Given this list of marker genes Tacc1 (NCBI Gene Id 78791), Emx2, Dock7, Hhex, Pax6, Akna, Ncor2, Tacc2, Hook3, Gli3, Pou3f3, Arx, Wnt7b, Numb, Kif1a, Ngf, Dixdc1, Dct, Rrm1, Fgf8, Nfib, Disc1, Fgfr2, Lhx5, Numbl, Six3, Tacc3, Zeb2, Nfix, Fgfr1, Fabp7, Kif14, Hmga2, Pcm1, Pou3f2, Wnt3a (wingless-type MMTV integration site family, member 3A), Igf2bp1, Wnt7a, Cep120, here is a description of the gene set: Mouse Gene Set: GOBP_CELL_PROLIFERATION_IN_FOREBRAIN studied in species Mus musculus The creation of greater cell numbers in the forebrain due to cell division of progenitor cells.